The following is a description of a gene set: Mouse Gene Set: SOX6_TARGET_GENES studied in species Mus musculus Genes containing one or more binding sites for (Sox6) in their promoter regions (TSS -1000,+100 bp) as identified by GTRD version 20.06 ChIP-seq harmonization. from publication Yevshin I, Sharipov R, Kolmykov S, Kondrakhin Y, Kolpakov F (PMID 30445619), and this is the list of marker genes: Magi1, Clasp1, Cacnb2, Zfp367, Sumo3, Gm15564, Arhgap18, Mybpc1, R3hdm1, Tnnt1, Tmem120b, Gm8041, Gm26626, Ndel1, Hdac9, Gm1720 (predicted gene 1720), Gm14137, Ptprf, Dap, Etv6, Met, Gm14092, Caprin1, Aloxe3, Uap1l1, 4833445I07Rik, Lpcat3, Fdps, Cep170, Rassf7, Dll1, Notch4, BC043934, Mast2, Wdr77, Sorbs2 (sorbin and SH3 domain containing 2), Hspb2, Ccdc93, Mir7663, Gm5547, Myl12a, Pttg1ip, Fgd4, Gm7656, Gm9961, Akt1, St3gal2, Zfp292, Thop1, Gm13754, Pbxip1, Tnrc18, Chn2, Myl4, Stk10, Ppp2r3a, Acyp1, Sdccag8, Hnrnpl, Gm17800, Prss33, Hoxa9, Gm11628, Tnnt2, Cnot6l, Mir5100, Naglu, Ablim2, Mir7672, Foxp1, Mir1968, Aknad1 (NCBI Gene Id 329738), Neurl2, Stk36, Pkig, Gm15826, Plcg1, Arl5a, Tnni1, Safb, Fbxl12, Pitpna, Ift81, Wls (NCBI Gene Id 99763), Angpt1, Mtf2, Adam19, Shb, Cln8, Gm12530, Igfbp2, 2810442N19Rik, Gm28411, Tob1, Gm22516, Ptma, BC034090, Myh8, Lysmd4, H4c16, Strit1, Akr1b10, 9430073C21Rik, Iqcg (NCBI Gene Id 69707), Ablim1, Myh1, Foxk2, Aox3, Svil, Myo10, Cables2, Mir1961, Apbb1, Nudcd3, Dhx32, Gm29346, Acox3, Jph1 (junctophilin 1), Gm11269, Smim22, Dzip1, Pde12, Mir206, 1700067K01Rik, Lmo7, Iffo1 (NCBI Gene Id 70822), Tedc2, Top3a, Pim2, 1110002E22Rik (RIKEN cDNA 1110002E22 gene), Snhg5, Runx1, 1500015L24Rik, 9930004E17Rik, Fbxl19, Scrib, Gm25630, Gm13551, Mir3109, Gm5641, Lincmd1, Chrna1 (cholinergic receptor nicotinic alpha 1 subunit), Hipk2, Ubl5 (NCBI Gene Id 66177), Mfhas1, Atosb, Pin4, Fbxw7, Irak2, Inava (innate immunity activator), Hjv, Ky, Cep41, Fmo1, Sema6a, Rnf122, Tspyl1, Glis3, C1qtnf3, Flii, Asb15, Limch1, Gm15462, Six2, Hes6, Chrng, Rab40c, Gm11661, Tcf4, Art1, Cytip, Ehbp1, Mir133b, Laptm4a, Gm19582, Synpo2, Gm14221 (NCBI Gene Id 105244348), Tmem9, Tspan9, Ctsa, Enah, Sox5, Kcnk2, Myh3, Acta2, Gm17072, Actc1dt, Zfand5, Altre, Chchd3, Prtn3, Manba, Plec, Tlk2, Myh7, H4c11, Rrp15, Otub2 (OTU domain, ubiquitin aldehyde binding 2), Snapc3, Musk, Pold2 (polymerase (DNA directed), delta 2, regulatory subunit), Cd109, Sash1, Trappc3, Nuak1, Slc12a8, Tecrl, Lrrc30, C030013C21Rik, Abcg2, St7, Mief2 (NCBI Gene Id 237781), Slc1a5, Dapk3, Tbc1d1, Ston2, Ndufaf3, Cmah, Hdac11, Trim54, Smcr8, Gm14004, Actc1 (actin, alpha, cardiac muscle 1), Pla2g6, Smim6, Ltbp1